The following is a description of a gene set: Genes detected by RT-PCR showing similar changes in lung adenomas and lung adenocarcinomas. Tissue is from lung adenocarcinomas from female A/J mice. from publication Yao R, Wang Y, Lubet RA, You M (PMID 12173053) Mouse Gene Set: YAO_AJ_MOUSE_LUNG_TUMOR_PROGRESSION_SIMILAR_ADENOCARCINOMA_UP Female A/J mice received a single i.p. injection of N-methylnitrosourea (MNU) in acidified saline (pH 5.0) at a dose of 50 mg/kg body weight. studied in species Mus musculus, and this is the list of marker genes: Map2k1, Cd44, Ccnb2, Prkcd, Cdk4, Ttf1, Ccnd1